The following is a description of a gene set: Any process that modulates the rate, frequency or extent of SMAD protein signal transduction. studied in species Homo sapiens Human Gene Set: GOBP_REGULATION_OF_SMAD_PROTEIN_SIGNAL_TRANSDUCTION, and this is the list of marker genes: GDF11, BMP2, DAB2, LRP1, MIR204, SPTBN1, BMP5, MIR26A1, PPARG, CSNK2B, GDF15, TTK, INHBA (inhibin subunit beta A), CCN3, LDLRAD4, TBX20, TGFB3, MIR199A1, GDF7, GDF5, PSG9, TGFBR2, NODAL, PMEPA1 (NCBI Gene Id 56937, prostate transmembrane protein, androgen induced 1), BMP4, PIN1, MIR146A, UCMA, ACVR1, KIAA0319, ACVRL1, NUP93, MIR23A, TOB1, AMH, JAK2, TWSG1, MIR140, EMILIN1, MIR323A, MIR101-1, OVOL2, EID2 (EP300 interacting inhibitor of differentiation 2), BMPR1A, DKK1, VEPH1, TGFB1, PARP1, BMP7, BMPER, TGFBR1, ACVR2A, SMAD7, BMP6, XBP1, SMAD3, MIR130A, MIR26B, HFE, MIR885, GREM1, FAM89B, GDF6, MIR195, TGFB2, CILP, SKI, BMPR2, MIR27A, MIRLET7G, NOG, SH2B1 (NCBI Gene Id 25970), GLCE, ATOH8, MIR145, SMAD6, CRKL, ENG, BMP10, MIR483, SMAD4, TGFBR3, GDF2, MIR205